Given this list of marker genes Ttyh1, Th, Kcnn2, Canx, Ryr1, App, Calr, Mapk8ip3, Jph4, Rpl10-ps3, Svip, Syvn1, Pdia6, Hsp90b1, Ppib, Hspa5, Gabarap, Ryr2, Napepld, Pdia3, Stx17, Myo5a, Rtn1, Plcb4, Aqp8, Itpr1 (inositol 1,4,5-trisphosphate receptor 1), Dmtn, Ryr3, Rpl10, Hyou1, Dnajc3, Erp29, Psen1, Ftcd, Prdx4, Pdia4, Aldob, here is a description of the gene set: The smooth endoplasmic reticulum (smooth ER or SER) has no ribosomes attached to it. The smooth ER is the recipient of the proteins synthesized in the rough ER. Those proteins to be exported are passed to the Golgi complex, the resident proteins are returned to the rough ER and the lysosomal proteins after phosphorylation of their mannose residues are passed to the lysosomes. Glycosylation of the glycoproteins also continues. The smooth ER is the site of synthesis of lipids, including the phospholipids. The membranes of the smooth ER also contain enzymes that catalyze a series of reactions to detoxify both lipid-soluble drugs and harmful products of metabolism. Large quantities of certain compounds such as phenobarbital cause an increase in the amount of the smooth ER. studied in species Mus musculus Mouse Gene Set: GOCC_SMOOTH_ENDOPLASMIC_RETICULUM